The following is a description of a gene set: Abnormal atrial arrangement Abnormality of the spatial relationship of the atria to other components of the heart. Human Gene Set: HP_ABNORMAL_ATRIAL_ARRANGEMENT studied in species Homo sapiens, and this is the list of marker genes: CFAP300, DRC1, CFAP74, FOXJ1, TTC12, RSPH3, ODAD1, PKD1L1, LRRC56, DNAAF5, NEK10, DNAAF3, ODAD2, NME5, RPGR, GAS2L2, DNAI1, DNAH9, SPAG1, CFC1, ZMYND10, MCIDAS, CCDC40, DNAH11, CCNO, RSPH4A, DNAAF11, CCDC39, CFAP298, HYDIN, RSPH1, DNAAF6, DNAH5, ODAD3, DNAI2, GDF1, DNAAF1, DNAAF2, DNAJB13, ZIC3, STK36, SPEF2 (NCBI Gene Id 80192), DNAH1, CFAP221, NME8, ODAD4, OFD1, NODAL, RSPH9, DNAAF4, DNAL1